The following is a description of a gene set: species: Homo sapiens Human Gene Set: SOX3_TARGET_GENES from publication Yevshin I, Sharipov R, Kolmykov S, Kondrakhin Y, Kolpakov F (PMID 30445619) Genes containing one or more binding sites for (SOX3) in their promoter regions (TSS -1000,+100 bp) as identified by GTRD version 20.06 ChIP-seq harmonization., and this is the list of marker genes: GNG2, WDR7, LRRC3-DT, SNX8, TUBB, LINC01560, TMEM202-AS1, RN7SKP295, TCEANC, RNU5A-1, H4C4, RBM39, FILIP1, BFSP1, YLPM1, SCOC, HCG14, MIR302A, ZPR1, TLE1, CAPN5, HNMT, ERCC6L2-AS1, GTPBP1, BTBD8, LINC02562, RIIAD1, GLYCTK-AS1, ZNF564, CAND1, ITGB8, KLF7 (KLF transcription factor 7), PRMT5-DT, HINT3, LINC02335, TLE4, PRCC, CCT2, TSHZ1, NKIRAS1, PRH1, RNF167, OTUD3, PPP3R1, DMD, ITGB1-DT, CYTH2, HNF1A-AS1, PELI1, RAB30, GRK6, TMEM143, RBBP6, ZBTB5, H3-3A, HOXB3, FBXO21, SRSF10, PRKG1-AS1, VMP1, FAM220A, PIGB, RN7SL577P, PTCH1, HMGB1, ENSG00000275765, EIF4A3 (NCBI Gene Id 9775), SNRPN, RASAL2, ZNF862, MAPK10, MRPS18B, ZNF775, CNTN6, MED1, NAA40, ATP8B4, RAB2A, LINC02208 (long intergenic non-protein coding RNA 2208), TMCC1, TUBA1C, ARPC4, SORBS2, ENSG00000214650, CSPP1, PLK2, BBS12, MMP10, CSRNP2, BLOC1S5, TMEM132B (NCBI Gene Id 84462), AGO3, HNRNPL, IREB2, MIR7845, MIR100HG, DCTN2, MIR302D, ABCC4, ID2-AS1, RPL17, SLC25A25, LURAP1L-AS1 (LURAP1L antisense RNA 1), EPS8L1, RBP1, ENAH (ENAH actin regulator), MAGED1, LINC00901, GRIA1, FCHO1, YOD1, OXR1, RGR, TSPYL4, DTNA, CFAP141, LARS1, DISP1, MEG3, GNA12, COPS5, RPL15P22, SREBF1, BTG1-DT, FKBPL, ABHD17B, MEF2C, PGRMC2, HES6, LETM2, ZNF295-AS1, NKTR, UBE2E1, DLGAP2, SPATS2L, COA1, LRRC77P, SWSAP1, CFAP276, SLC35F4, DLGAP1-AS2, CHD2, ACACA (acetyl-CoA carboxylase alpha), C14orf132, TUBGCP5, NF2, CFAP70, VANGL2, CEP41, LINC01414, ASMTL, TIAM2, PTK2, DAD1, EPS15 (epidermal growth factor receptor pathway substrate 15), H3-3A-DT, TMEM94, NAA38, LSM11, LLPHP2, ENSG00000230725, ZNF410, LRRC3, RBM15, FOXO6, DDR1 (discoidin domain receptor tyrosine kinase 1), CELF3, THG1L, C10orf120, ARL16, SUGT1P1, USP34, LINC02901, LINC01708, PDZPH1P, CDK12, NCOA4, ZNF475 (NCBI Gene Id 730724), KIFBP, MTHFD1, FGD4, NME1, COX7B, MID1, SMARCA2, NECTIN3, PPP1R10, NR2F1, ANKRD44, PPP1R16B, NME1-NME2, PLEKHG1, TMUB2, SPRY4-AS1, SPINK5, GET3, XPR1 (xenotropic and polytropic retrovirus receptor 1), RORA, ERCC6L2 (NCBI Gene Id 56959), AP2A2, TFDP2, MASP1, MAP1B, ATPSCKMT, MKKS, PSME3IP1, AKAP10, PIP5K1B, ATP10B, PRMT5, SNRPGP6, LSM4, CETN4P, ITPR1, DSE, STAT6, WWP1, MIR4322 (NCBI Gene Id 100422925), SPDL1, PTP4A1, MPP1, FAM181A, CLIP1, ATP2C1, RSPH14, CCDC192, SLX4IP, METTL15, MSI2, RNU6-92P, DTD2, RSPRY1, ZNF189, C9orf85, LINC02926, ARIH1, NCOR2, RNY3, S100A2, MRPL50, GCNT3, TMEM109-DT, TRAV40, ANAPC15, TIAL1, ATXN2L, LNC-LBCS, SAR1AP4, GPM6A, WDR49, AASS, LINC02453 (NCBI Gene Id 651743), GULP1, TMEM18, MED24, BTG1, RBBP5, ELAPOR1, TANK, BLOC1S5-TXNDC5, ANKS4B, GRHL1, PRR5L, SOX1-OT, C1orf21, MIR4677, SOX2-OT, PNMA8C, LIG1, SRSF7, SCOC-AS1, DYNC1I2, TXNRD2, ENSG00000271551, NRP2-AS1, ABCF2, DTHD1, DICER1, EMSY, BRAF, SEPSECS-AS1, MLEC, PRKCI, EID1, EDDM13, CDCA4, DZANK1, B3GNT5, BACH2, SNORD58B, STAP2, CBX1, SCAT2, RNU6-270P, NUP214, MIR9-2HG, VCPIP1, AKAP6, ENSG00000201410, PFKFB2, MSI1, C11orf58, MACC1-AS1, SPRY4, ACSL6-AS1, CTIF, PHB2, RRAS, SLC25A11, SLC15A3, FBXL19, ZNF622, KANSL1L, PLBD1, CEP128, MYO9A, SEPSECS, PUF60, ZNF41, CYB5D1, SART3, JUP, IFI16, PSMD1 (proteasome 26S subunit, non-ATPase 1), GPR19, FXYD1, SHC4, NRP2, RNF5, HBP1, AP2A1, FMN2, LINC00446, HSPH1, ZC3H12C, PDE4B, FNDC3B, GANC, AP2S1, RPL31P24, ZNF709, MMACHC, INTS9, CPEB4, SEH1L, BCOR, ZBTB20, NECTIN3-AS1, ATF7IP, CD300LD-AS1, PCNPP2, SYNGR4, STK32C, DOK6, CTNND2, SCHIP1, ANGPT1, NFKBIZ, PURB, HHIP, RPL15, ARAP3, MAFK, MRPS27, RNU6-1, FUZ, FYN, ATP5PB, PLK3, ARRDC3, SUMF1, ZDHHC5, MIR550B1, MCTP1, WDR77, PPIP5K2, PDP1, LINC01396, MIR219A2HG, PIPOX (NCBI Gene Id 51268), TNRC18, PRR4, SERPINB9P1, SOX6, TMEM231, ARID1B, EGFEM1P (EGF like and EMI domain containing 1, pseudogene), SH3RF2, C5orf22, ZFAND5, GPC2, ZNF474, TAGLN3 (transgelin 3), SAMD9, CCDC163, STOX2, DKK1, ALOXE3, LINC00649, FEM1A, DIAPH3 (diaphanous related formin 3), CFAP20, G3BP1, GSE1, ZFAND6, PACRG-AS1, ENC1, ETV4, APC, ITFG2, AGFG1, EMG1, KANSL1-AS1, PNRC1, CHN2, MORF4L1, GLA, H2BC8, FZD2, IER5L, ALG10, CNOT8, TRAPPC9, NAIF1, CCT5, ANXA2, ZNF217, ENSG00000239482, RN7SKP134, PFKM, NDST4, ZNF44, GEMIN6, SYBU, PDHX, OSBPL2, RPL17-C18orf32, HNRNPH2, HSPD1P9, KIF18A, MIR378D2HG, PET100, CCDC42, SUMO2, SYAP1, CRABP2, RFX4, MIR367, EMSY-DT, SOX5, MEGF8, GOLIM4, RAB11A, CHCHD3, STRIP1, RAD51AP2, HDGF, CARD10, C1orf226, SPHK2, STMN1, HEG1, MIR106AHG, SDC2, MIR325HG, HGS, MBP, TAS2R14, TCIM, AGR3, EEF1A1, FOXP4, MTF2, RAB30-DT, CNN3, LSM8, ZZZ3, HMGCR, AP3D1, AP1G1, SEPTIN9, ADNP, MIR302CHG, PANX1, EML2, KCND3-AS1, EDRF1, LINC01619, SLC6A6, SIX2, KCNH7-AS1, CCN2, MIR302C, MAT2B, PTH2R, RIOK1, SLC33A1, COPB2-DT, TOMM40, COQ6, ITFG2-AS1, THBS3, EDRF1-DT, ETV1, LINC02265, CLYBL-AS2, CDH11, ABCC9, PHLDB2, TNKS, CNKSR3, SMC6, SDCBP2 (NCBI Gene Id 27111), FAM181A-AS1, PHF12, HMBOX1, WBP1L, H2AC8, BPTF, ITGB1, LFNG, PVT1, MFSD6, TMED9, PYROXD1, TMBIM6, RPS11, UQCC6, PTDSS2, LRRC27, MPP7, NNMT, ASB16-AS1, BCAT1, EIF3B, BTBD10, DMWD (NCBI Gene Id 1762), ACOX3, RNFT1, MIR3913-1, STAG3, DMXL2, RMND5A, SPAG9, FRAT1, PPP2R2B (protein phosphatase 2 regulatory subunit Bbeta), PPP1R15A, UACA, ZSCAN2 (NCBI Gene Id 90393, zinc finger and SCAN domain containing 2), XAB2, ZW10, COL15A1, AKAP13 (A-kinase anchoring protein 13), ZNF57, AGPAT1, LINC02831, IPO11, ALG8 (ALG8 alpha-1,3-glucosyltransferase), KIF21A